The following is a description of a gene set: Reactome Pathway: Transcriptional Regulation by NPAS4 species: Mus musculus part of: Generic Transcription Pathway This event has been computationally inferred from an event that has been demonstrated in another species.<p>The inference is based on the homology mapping from PANTHER. Briefly, reactions for which all involved PhysicalEntities (in input, output and catalyst) have a mapped orthologue/paralogue (for complexes at least 75% of components must have a mapping) are inferred to the other species. electronically inferred by orthology from the curated human pathway, and this is the list of marker genes: Bmal1, Maged1, Npas4, Arnt2